The following is a description of a gene set: Human Gene Set: GOBP_OTIC_VESICLE_MORPHOGENESIS The process in which the anatomical structures of the otic vesicle are generated and organized. The otic vesicle is a transient embryonic structure formed during development of the vertebrate inner ear. species: Homo sapiens, and this is the list of marker genes: SOX9, EYA1, STOX1, CEP290, PROX1, FGFR2, FGF8, FGF10, HESX1, TCAP